Given this list of marker genes D330050G23Rik, Ugdh, Cdh6, Adamts5, Pramel47, Sox10, Tspan7, Pls3, Cdk18, Dagla, Moxd1, Heyl, Pmepa1, Zeb2os, Ednrb, Apc-ps1, Cdh19, Pebp4, Eeig1, Adgrg6, Fhdc1, Egfl8, Scrg1 (scrapie responsive gene 1), Bcar3 (NCBI Gene Id 99553), Lgi4, Mpz, 2010320O07Rik (RIKEN cDNA 2010320O07 gene), D7Ertd443e, Erbb3, Sfrp5, Gm10863, Foxd3, Sntb1, Cyp2j8, AA914427, Ubl3, Gjc3, Hcn1, Btbd3, Fign, Shc4, Gpr17, Sema3b (NCBI Gene Id 20347), Gm16168, Slitrk6, Slitrk2, Tmem117, Gm29507, Megf9, Itprid2, Plekha4, Stard13, Gm19514, Serpine2, Arhgef26, Gm29865, Pde7b, Gm10046, Car11, Rasa2, Olfml2a, Atp10b, Tmprss5, Gm12688, Cyp2j9, Mal, Chst5, Cmtm5, Iqch, Afap1l2, Hey2, Kcnk5, Ifit2, Col20a1, Insc, Matn2, Luzp2, Prss12, Plp1 (NCBI Gene Id 18823), Gpr37, 4930505M18Rik, Gfra3, Art3, Otud1, Entpd2 (NCBI Gene Id 12496), Fam107a, Deptor, Cyp2j6, 5031415H12Rik, Raet1e, Gfra2, Wdfy1, Lmo4, Col28a1, Prima1, here is a description of the gene set: species: Mus musculus Mouse Organogenesis Cell Atlas (MOCA) DE_gene_main_cluster.csv, fold.change>=1.5, qval<0.05, pval<0.05 Mouse Gene Set: DESCARTES_ORGANOGENESIS_SCHWANN_CELL_PRECURSOR from publication Cao J, Spielmann M, Qiu X, Huang X, Ibrahim DM, Hill AJ, Zhang F, Mundlos S, Christiansen L, Steemers FJ, Trapnell C, Shendure J (PMID 30787437)